The following is a description of a gene set: Human Gene Set: MODULE_447 Genes in the cancer module 447. studied in species Homo sapiens, and this is the list of marker genes: CCT2, EIF3E, TAGLN, CTNNA1, KRT8, IGFBP3, ECI1, NPTXR, NFKBIA, RHOJ, LCOR, RBPJ, EIF3H, EIF3C, FAF1, EIF3D, EIF3F, ID2, ZMPSTE24, YME1L1, IGFBP2, NOLC1, CTBP2, C4A, SEC61B, EEF1B2, BNIP3, RSRP1, SNRPA, DGCR2, UQCR11, ANXA5, DYNLT1, BMS1, RPL29, GPS2 (G protein pathway suppressor 2), COL4A2, EIF3I